Given this list of marker genes Shh, Sfrp2, Scx, Pax1, Meox1, here is a description of the gene set: studied in species Mus musculus The progression of the sclerotome over time, from its initial formation to the mature structure. The sclerotome is the portion of the somite that will give rise to a vertebra. Mouse Gene Set: GOBP_SCLEROTOME_DEVELOPMENT